The following is a description of a gene set: species: Homo sapiens Genes up-regulated in wildtype bone marrow-derived macrophages treated with rosiglitazone: control versus IL4. Conditional macrophage-specific PPARg knockout mice were generated on C57Bl/6 background by breeding PPARg fl/- (one allele is floxed, the other is null) and lysozyme Cre transgenic mice. PPARg and IL-4 signaling was analyzed on bone marrow-derived macrophages. Bone marrow of 3 mice per group was isolated and differentiated to macrophages with M-CSF (20 ng/ml). 20 ng/ml IL-4 was used to induce alternative macrophage activation and 1 uM Rosiglitazone (RSG) was used to activate PPARg. From each mouse 4 samples were generated: 1. M-CSF, 2. M-CSF+RSG, 3. IL-4 and 4. IL-4+RSG. All compounds were added throughout the whole differentiation process, and fresh media was added every other day. Control cells were treated with vehicle (DMSO:ethanol). After 10 days, RNA was isolated and gene expression profiles were analyzed using Mouse Genome 430 2.0 microarrays from Affymetrix. from publication Szanto A, Balint BL, Nagy ZS, Barta E, Dezso B, Pap A, Szeles L, Poliska S, Oros M, Evans RM, Barak Y, Schwabe J, Nagy L (PMID 21093321) Human Gene Set: GSE25123_ROSIGLITAZONE_VS_IL4_AND_ROSIGLITAZONE_STIM_MACROPHAGE_DAY10_UP, and this is the list of marker genes: ZNF146 (NCBI Gene Id 7705), PLEK, PDCD10, MRPS5, TUBGCP4 (tubulin gamma complex component 4), TIMMDC1, RAB5IF (NCBI Gene Id 55969), SPAG5, XAB2, KCTD12, ID2, BCCIP, WSB2, COA8, CREG2, GALNT1, QSOX1, GARS1, UBASH3B, ZDHHC5, UBASH3A, PCDH11X, SH2D1A, ZMPSTE24, TAF9B, LSAMP, CCDC86, CPPED1, LUZP2, TOP2A, MESD, PEPD, KIFC1, GPATCH3, FAT4, KIF4A, HSBP1, TUBB, ANKRA2, HIC1, VPS35L, CEP126, DHX38, NSD2, CDCA4, ADGRG5, MEAK7, ADCY3, LRRC59, GLYCTK, PARP1, BUB1B, SLC25A6, SUGT1, EIF3E, SNX25, ADI1, MKRN2, PITRM1, TBC1D5, CHAF1B, TCOF1, CFAP95, PAPSS1, RORC, POGLUT3, CYP2S1 (NCBI Gene Id 29785), VPS33A, EZH1, CNDP2, SCFD1, PRPF8, ST7, HGSNAT, GLIS1 (NCBI Gene Id 148979), SWSAP1, RPS6KC1, ABCB1, CDKL4, CAPN2, DHX58, SLC35F2, FBXO16, SLC39A11, VWA5A, TPM3 (NCBI Gene Id 91191), NUP214, ECD, LPAR3, MAP2K5, RDH11 (retinol dehydrogenase 11), SLC38A4, KCNK5, NFATC3, TRAPPC4, LRRC66, GPAT3, MMD, COPS4, PPIA, SEC24D, GZMK (granzyme K), ABAT, MYBL2, ASB2, RIMS3, PPCS (phosphopantothenoylcysteine synthetase), EVI2A, FER, EIF3H, GABRR1, SORD, RRP8, STAMBP, GNE, NARF, STK39, SLC25A30, EMX1, MPZL3, ACSF3, GUSB, EEF1D, TRAM1, PCDHB16, DDX25, ZNF839, MAPKAP1, ATP6V1C1 (NCBI Gene Id 528), ATP6V1A, PEX13, FUOM, IGSF9B, CPZ, GOLT1B, PELO, CCDC102A, FECH, PHKG1, SNN, GYPC, ARL4A, NUDT4, FAM72A, SEC14L1, CNIH1 (NCBI Gene Id 10175), SKAP2, PTPN3, PCDHB13, NSMAF, CMPK2, MLEC, FICD, BAG6, EXT1, SERPINB1, ZNF426, LMAN1, EPDR1, GIMAP6, TFDP1, VHL, C1orf131, GJB2, CCT5, SNRNP35, RDH12, AAR2, MME, FUCA2, UBXN8, PDCL3, SNX10, SMG8, SMYD5, SELENOF, WASHC5, NUP88, AFG1L, NOP9, RTN4RL1, SNX14, PHYH, NABP1, ONECUT2, CYSLTR1, VPS53, DRG1, GALNT14 (polypeptide N-acetylgalactosaminyltransferase 14), PIP5K1A, PTGER2, IKBKG, PRMT6 (protein arginine methyltransferase 6), RASL11A, IL1R1, CXCR5, DYM, EIF4H, POU2AF1